Given this list of marker genes Pitpnm2, Agpat1, Ptdss1, Pla2g3, Mfsd2a, Pla1a, Mboat2, Gpd1, Pitpnb, Pitpnm3, Pgp, Pla2g1b (NCBI Gene Id 18778, phospholipase A2, group IB, pancreas), Pla2g4d, Pemt, Ddhd2, Hadha, Mboat7, Lclat1, Pla2g12a, Chpt1, Lpcat4, Abhd3, Awat2, Pnpla8, Plbd1, Pcyt1a, Pld2, Pla2g5, Stard10, Slc44a3, Pnpla3, Alpi, Pla2g2a, Pla2g2f, Osbpl10, Chkb, Csnk2b, Pld6, Slc44a4, Pcyt2, Pla2g6, Lipi, Dgat2l6, Cds1, Pcyt1b, Pla2g2e, Agpat4, Pla2g2d, Lpcat2, Gpam, Cpne6, Agpat3, Tmem86b, Ptdss2, Slc44a2, Chka, Dgat2, Pla2g4f, Pla2r1, Osbpl5, Gpat2, here is a description of the gene set: Reactome Pathway: Glycerophospholipid biosynthesis electronically inferred by orthology from the curated human pathway This event has been computationally inferred from an event that has been demonstrated in another species.<p>The inference is based on the homology mapping from PANTHER. Briefly, reactions for which all involved PhysicalEntities (in input, output and catalyst) have a mapped orthologue/paralogue (for complexes at least 75% of components must have a mapping) are inferred to the other species. studied in species Mus musculus part of: Phospholipid metabolism